The following is a description of a gene set: species: Homo sapiens Human Gene Set: HP_ABNORMALITY_ON_PULMONARY_FUNCTION_TESTING Any anomaly measure by pulmonary function testing, which includes spirometry, measures of diffusing capacity, and plethysmography. Abnormality on pulmonary function testing, and this is the list of marker genes: DNASE1L3, FARSA, GLT8D1, VAPB, TRAPPC11, SFTPA2, SLC6A14, DPP9, SUFU, HFE, PON1, PRPH, RILPL1, AK9, SCNN1B, RAPSN, RNU4ATAC, TOR1AIP1, NLRP3, DMD, MYOT, ARSB, GGPS1, DSP, TSC2, CEACAM6, BAG3, PUS1, CHMP2B, TINF2, CRPPA, BTNL2, CD81, SELENON, FAM111B, POGLUT1, NOTCH2NLC, CEACAM3, SFTPC, PFN1, OPTN, CHRNA1, SCN4A, MESP2, FGFR3, ERBB4, CHRNE, PON2, NEFH, ATP11A, CHCHD10, DCTN1, CSF2RB, DNAH9, TGFB1, GCLC, TREM2, MYPN, STX1A, SLC11A1, CFTR, WDR19, ACTA1, FKRP, SLC12A6, NF2, COL2A1, CR2, HLA-DRB1, CD19, PRTN3, LRP12, GLB1, XYLT1, DKC1, MATR3, COL6A2, MEGF10, MIF, KBTBD13, BAP1, PLOD1, CSF2RA, TBK1, HLA-DPB1, POT1, DDR2, ENG, DCTN4, STN1, RTEL1, FLNB (filamin B), SMPD1, MUSK, RNF168, SLC26A9, CHRNB1, MS4A1, TOR1A, GLE1, FUS, LRP4, HPS4, MCIDAS, ADSS1, HMOX1, HES7, SMO, GSTM3, TSC1, SYT2, XYLT2, HNRNPA1, PDGFB, TPM2, ABCC6, SERPINA1, ANG, SMARCE1, ATXN2, MYO1H, SYNE1, PON3, MYH7, STK36, EDNRA, SCNN1G, COPA, KCNN4, SLC34A2, FAM13A, FIG4, DOCK11, PARN, ITCH, MEG3, B3GALT6, JAG2, DNAH11, MAP3K20, AKT1, SLC25A21, GALNS, PIK3CA, SMARCB1, DLK1, NEK10, HLA-DPA1, TNFRSF13B, TERC, SFTPA1, PIEZO2, PTPN22, PABPN1, RTL1, GNPTAB, ICOS, MUC5B, TAF15, UNC45B, SLC9A3, DUX4, SQSTM1 (sequestosome 1), NFKB1, ALMS1, PYROXD1, DNMT3B, SCNN1A, NKX2-1, SBF2, CHRND, CTLA4, SMCHD1, RPA1, IDS, MT-TL1 (mitochondrially encoded tRNA-Leu (UUA/G) 1), TNNT1, TARDBP, HPS1, NEB, HLA-B, AGRN, EIF2AK4, NFKB2, CLCA4, TPM3, HCK, TRIP4, FCGR2A, NEK1, UNC13A, ACP5, ABCA3, TNNC2, CCNF, NAA10, KLHL41, STAC3, NDUFAF6, IRF2BP2, DOK7, MT-TL2, ACTN2, TNFSF12, MT-TN, TERT, PPARGC1A, FRG1, DUX4L1, CFAP410, GIPC1, DAO, TTN, TRAF7, UBQLN2, TNFRSF13C, COL13A1 (collagen type XIII alpha 1 chain), SOD1, GDAP1, SNUPN, IKZF1 (IKAROS family zinc finger 1), BICD2, ANXA11 (annexin A11), SGCG, VCP